Given this list of marker genes REG1B, ITLN2, REG1A, SELL, LGALS9, SELP, LOXL2, REG3A, ITLN1, CHID1, COLEC11, SELE, LGALS3, LGALS1, LGALS12, REG3G, LGALS16, here is a description of the gene set: Binding to an oligosaccharide, a molecule with between two and (about) 20 monosaccharide residues connected by glycosidic linkages. Human Gene Set: GOMF_OLIGOSACCHARIDE_BINDING studied in species Homo sapiens